Given this list of marker genes ABCE1, EIF4A2, EIF3I (NCBI Gene Id 8668), MCTS2, MCTS1, EIF6, DDX3X, DHX33, NCBP1, EIF1, ATF4, HHEX, EIF5B, BZW2 (NCBI Gene Id 28969), EIF3CL, EIF4EBP2, EIF3M, BZW1, BOLL (NCBI Gene Id 85404), SH3BGRL, LTO1, PPP1CA, EIF5 (NCBI Gene Id 1983), C8orf88, YTHDF2, EIF2AK1, RPS6KB2 (ribosomal protein S6 kinase B2), CCL5, EIF4E3, EIF3A, MIF4GD, EIF3H, YTHDF1, EIF4B, EIF2B5, EIF4G2, DAZ1, MTIF3, RPS17, EIF2AK4, TNF, AKT2, EIF2S3B, DDX1, DAZ4, PKP1, COPS5, EIF3G, RPL13A, EIF4E1B, METTL3, PAIP2B, ABCF1, EIF2S1, EIF2B2, EIF2B3, EIF3J, RPS3A, EIF1AX, EIF2AK3, EIF3B, EIF4G1, CSDE1, EIF3F, EIF1B, PAIP2, EIF3E, HSPB1, PML, BANK1, EIF2D, KHDRBS1, POLR2G, PAIP1 (poly(A) binding protein interacting protein 1), SCRIB, MTFMT, EIF3C, EIF4EBP1, EIF2B1, CTIF, EIF4H, FMR1, RPS5, EIF4E2, METAP2, NCK1, EIF2B4, NCBP2, EIF4EBP3, ZNF598, PPP1R15A, KLHL25, DAZL, EIF2S3, EIF2S2, DAZ2, NPM1, UHMK1, DAZ3, EIF3D, MTIF2, DENR, GIGYF2, SLBP, EIF1AY, HABP4, EIF3L, RPS6KB1, DNAJC3, EIF2AK2, MTOR, EIF2A, RBM4, EIF4E, RPS3, AGO2, IMPACT, TPR, DHX29, LARP1, EIF1AD, YTHDF3, NCK2, ALKBH1, EIF4A1, EIF3K, EIF4G3, here is a description of the gene set: Human Gene Set: GOBP_TRANSLATIONAL_INITIATION The process preceding formation of the peptide bond between the first two amino acids of a protein. This includes the formation of a complex of the ribosome, mRNA or circRNA, and an initiation complex that contains the first aminoacyl-tRNA. studied in species Homo sapiens